The following is a description of a gene set: species: Mus musculus Mouse Gene Set: GOCC_STEREOCILIUM_BASE The tapered base of the stereocilium adjacent to where it joins the hair cell body. This region contains a rootlet comprised of bundled actin filaments which spans the joint and stabilizes the stereocilium., and this is the list of marker genes: Myo7a, Pjvk, Grxcr2, Clic5, Ptprq (NCBI Gene Id 237523), Triobp, Tprn, Rdx